Given this list of marker genes CYP2D6, UGT1A7, NUDT15 (nudix hydrolase 15), GSTM2, CRYZ, GSTM3, CYP2C8, ACAA1, CYP2C9 (cytochrome P450 family 2 subfamily C member 9), ACSL1 (NCBI Gene Id 91249), UGT1A10, NOS1, CYP3A5, CYP2C19, CYP1A2, CYP1A1, CYP2B6, GSTM4, NR1I2, GSTO1, FMO4, GSTM1, CYP3A4, TPMT, CYP2A6, PRKCE, here is a description of the gene set: The chemical reactions and pathways resulting in the breakdown of a xenobiotic compound, a compound foreign to the organism exposed to it, carried out by individual cells. It may be synthesized by another organism (like ampicilin) or it can be a synthetic chemical. Human Gene Set: GOBP_XENOBIOTIC_CATABOLIC_PROCESS studied in species Homo sapiens